Given this list of marker genes Foxo4, Smad2, Foxo1, Foxo3, Smad3, Foxg1, Smad4, Foxo6 (forkhead box O6), here is a description of the gene set: studied in species Mus musculus FOXO-mediated transcription of cell cycle genes Mouse Gene Set: REACTOME_FOXO_MEDIATED_TRANSCRIPTION_OF_CELL_CYCLE_GENES